The following is a description of a gene set: Any signaling pathway that modulates the activity of a cell cycle cyclin-dependent protein kinase to modulate the switch from G2 phase to MI phase of the meiotic cell cycle. Mouse Gene Set: GOBP_REGULATION_OF_G2_MI_TRANSITION_OF_MEIOTIC_CELL_CYCLE species: Mus musculus, and this is the list of marker genes: Cdc25a, Stk35, Cdc25c, Pkmyt1, Pdik1l, Usp17le, Cdc25b